The following is a description of a gene set: The lipid raft resident adaptor molecules LAT1 and Non-T cell activation linker (NTAL), also known as linker for activation of B cells (LAB)/LAT2 are known participants in the regulation of mast cell calcium responses. Both LAT and NTAL are expressed and phosphorylated following engagement of FCERI on mast cells. NTAL is functionally and topographically different from LAT. There is a considerable debate on the role of NTAL in mast cell. Depending on the circumstances, NTAL appears to have a dual role as positive and negative regulator of MC responses elicited via FCERI. Studies conducted in bone marrow-derived mast cells (BMMCs) of mice lacking NTAL displayed enhanced FCERI-mediated tyrosine phosphorylation of several substrates, calcium response, degranulation, and cytokine production. This indicated that NTAL negatively regulates FCERI-mediated degranulation. However, in mice lacking both LAT and NTAL showed severe block in FCERI-mediated signaling than BMMCs deficient in LAT alone, suggesting that NTAL also shares a redundant function with LAT to play a positive role. The major steps in NTAL mediated Ca+2 influx involves NTAL--> GAB2--> PI3K part of: Fc epsilon receptor (FCERI) signaling studied in species Homo sapiens Reactome Pathway: Role of LAT2/NTAL/LAB on calcium mobilization, and this is the list of marker genes: LAT2, IGHV3-53, IGKV2-29, SYK, IGKV3-20, IGLV3-1, IGKV4-1, IGLV2-18, IGKV1D-39, IGHV3-11, IGHV3-30 (immunoglobulin heavy variable 3-30), IGLV4-60, IGLV1-44, IGLV, IGKV1D-33, IGHV3-33 (immunoglobulin heavy variable 3-33), IGHV, SHC1, IGHV3-7, IGLV2-8, IGKV2D-40, PIK3R1, IGLV3-25, IGKV1-33, IGLC1, PIK3CA, IGLV2-33, IGKV1-5, PDPK1, IGLV7-46, IGLV5-45, IGHV7-81, IGHE, IGKV1-39, IGHV1-2, IGKC, IGLV1-47, IGLC6, IGLV2-11, IGLV7-43, IGLV4-69, IGLV6-57, IGHV3-13, IGKV5-2, IGLV5-37, IGHV3-48, IGKV2-30, IGLV3-22, IGKV1-17, IGHV4-39, IGLV3-27, FYN, IGLV1-40, IGKV2D-28, IGHV2-70, IGLV10-54, IGKV3-15, IGLV4-3, IGLV8-61, IGLV1-51, IGLC3, PIK3R2, IGLV1-36, LYN, IGLV2-14, GAB2, IGKV3-11, IGLV11-55, IGKV2D-30, IGLV3-12, IGHV4-59, IGKV1-12, IGLC2, FCER1G, IGLV3-16, IGHV2-5, IGHV4-34, FCER1A, IGKV3D-20, IGLV3-19, IGKV1D-16, IGHV1-69, IGLC7, IGHV3-23, IGHV3-9, IGHV1-46, IGKV1-16, IGLV2-23, IGKV2-28, IGKV1D-12, MS4A2, IGLV3-21, PIK3CB, GRB2, SOS1